The following is a description of a gene set: The binding activity of a molecule that provides a physical support for the assembly of a multiprotein receptor signaling complex. studied in species Homo sapiens Human Gene Set: GOMF_SIGNALING_RECEPTOR_COMPLEX_ADAPTOR_ACTIVITY, and this is the list of marker genes: FRS2, GAB2, NCK2, GAB4, GRB10, CD3G, MMS19, DOK2, GRIP1, ROPN1B, DLG5, CARD10, PTPN11 (protein tyrosine phosphatase non-receptor type 11), SH2B3, HOMER2, SPAG9, GNB3, SHB, CRK, TRAT1, SH2B1, SHANK1, SHANK2, RGS14, IRS2, SPATA2, GNB1 (G protein subunit beta 1), PIK3R1 (NCBI Gene Id 5295), GRB2, TRADD, LRRK2, SHANK3, STAP1, SH2B2, CD3E, G3BP2, BLNK, MAGI2, NUP62, FRS3, LDLRAP1, DEDD2, NCK1, GNB4, GNB2, SHC1, GNB5, SORBS1, MAPK8IP3 (mitogen-activated protein kinase 8 interacting protein 3), CDH5, IRS1, LAT